The following is a description of a gene set: Human Gene Set: GOBP_POSITIVE_REGULATION_OF_VASCULAR_ENDOTHELIAL_GROWTH_FACTOR_PRODUCTION Any process that increases or activates the frequency, rate, or extent of production of vascular endothelial growth factor. species: Homo sapiens, and this is the list of marker genes: CXCL17, CYP1B1, BRCA1, ISL1, C3AR1, CCBE1, HIF1A, SULF1, BSG, HPSE, C5, SULF2, PTGS2, TGFB1, C5AR1, IL1B, RORA, RELA, IL6, IL1A, EIF2AK3, C3, ADORA2B, FLT4, IL6ST, ARNT, GATA4, NOX1, ATF4, MIR132, NODAL, STAT3